The following is a description of a gene set: The class A (rhodopsin-like) GPCRs that bind to classical biogenic amine ligands are annotated here. The amines involved (acetylcholine, adrenaline, noradrenaline, dopamine, serotonin and histamine) can all act as neurotransmitters in humans. The so-called 'trace amines', used when referring to p-tyramine, beta-phenylethylamine, tryptamine and octopamine, can also bind to recently-discovered GPCRs. species: Homo sapiens Reactome Pathway: Amine ligand-binding receptors part of: Class A/1 (Rhodopsin-like receptors), and this is the list of marker genes: HRH4, TAAR8, HTR1D, CHRM5, TAAR3P, HTR4, HTR5A, GPR143, TAAR2, DRD4 (dopamine receptor D4), DRD2, ADRB1, ADRA2B, HTR7, ADRB2, ADRA1B, CHRM4, CHRM3, HRH3, DRD5, CHRM1, HRH2, ADRA1D, HTR1A, ADRA2C, HTR6, DRD1, ADRA1A, TAAR9, HTR2C, HTR1B, TAAR1, HTR1F, HRH1, ADRB3, HTR2A (NCBI Gene Id 3356), TAAR6, CHRM2, HTR2B, HTR1E (5-hydroxytryptamine receptor 1E), TAAR5, DRD3, ADRA2A